The following is a description of a gene set: from publication Cui A, Huang T, Li S, Ma A, Pérez JL, Sander C, Keskin DB, Wu CJ, Fraenkel E, Hacohen N (PMID 38057668) Genes negatively differentially expressed in cell type: pDC (plasmacytoid dendritic cell) upon treatment with cytokine: TNF-α in mouse lymph nodes in vivo. species: Mus musculus Mouse Gene Set: CUI_PDC_TNFA_RESPONSE_DN Cytokines mediate cell-cell communication in the immune system and represent important therapeutic targets. A myriad of studies have highlighted their central role in immune function, yet we lack a global view of the cellular responses of each immune cell type to each cytokine. To address this gap, the authors created the Immune Dictionary, a compendium of single-cell transcriptomic profiles of more than 17 immune cell types in response to each of 86 cytokines (>1,400 cytokine-cell type combinations) in mouse lymph nodes in vivo. A cytokine-centric view of the dictionary revealed that most cytokines induce highly cell-type-specific responses. For example, the inflammatory cytokine interleukin-1β induces distinct gene programmes in almost every cell type. A cell-type-centric view of the dictionary identified more than 66 cytokine-driven cellular polarization states across immune cell types, including previously uncharacterized states such as an interleukin-18-induced polyfunctional natural killer cell state., and this is the list of marker genes: Btg2, Zeb2, Mvb12a, Upb1, Mef2c, Tyrobp, Pafah1b3, Ptpn18, Ubc, Plp2, Pacsin1, Runx2, Ptp4a3, Bst2, Cox7a2l, Cacna1e, Khk, Cmah, Klf2, Itm2b, Ctsb, Rgs10, Hspa1b, Ctsl, Ypel3, Ccr5, Naca, Hmgb1, Timp2, Alox5ap, Ubb, Adk, Atp1b1, Tsc22d1, Jund, Ramp1, Nop53, Sell, Fos, Ctsd, Fyn, Cox6a2